The following is a description of a gene set: studied in species Homo sapiens Leucine, isoleucine and valine metabolism Human Gene Set: WP_LEUCINE_ISOLEUCINE_AND_VALINE_METABOLISM, and this is the list of marker genes: AUH, ACAD8 (NCBI Gene Id 27034), HIBCH, HSD17B10, BCKDHA, BCAT1, ACADSB, BCAT2, HIBADH, ACSF3, DBT, ACAT1, MCCC2, HMGCLL1, PCCA, ECHS1, MMUT (NCBI Gene Id 4594), ALDH6A1, DLD, MLYCD, PCCB, BCKDHB, MCCC1, IVD